The following is a description of a gene set: Human Gene Set: HP_THORACIC_KYPHOSCOLIOSIS species: Homo sapiens Thoracic kyphoscoliosis, and this is the list of marker genes: CHRND, PCGF2, SPRTN, AK9, LMNA, CHRNB1, DES, SOX5, RAPSN, CHRNA1, AGRN, CHRNE, PYCR2, SCN4A, IARS2, MUSK, PLOD1, ZMPSTE24, COL13A1, LRP4, ADGRG6, DOK7, ITCH, NKX3-2